The following is a description of a gene set: The chemical reactions and pathways involving a deoxyribonucleotide, a compound consisting of deoxyribonucleoside (a base linked to a deoxyribose sugar) esterified with a phosphate group at either the 3' or 5'-hydroxyl group of the sugar. Mouse Gene Set: GOBP_DEOXYRIBONUCLEOTIDE_METABOLIC_PROCESS species: Mus musculus, and this is the list of marker genes: Tyms, Tbpl1, Nt5c3, Dpyd, Guk1, Dera, Nt5c1a, Cmpk2, Dguok, Dnph1, Nudt16, Ak2, Ak3, Nudt15, Urad, Dck, Rrm2b, Samhd1, Urah, Nt5c, Adk, Dut, Rrm2, Rrm1, Nudt18, Nme2, Dctpp1, Pnp, Uox, Upp1, Upb1, Nme1, Nt5c2 (5'-nucleotidase, cytosolic II), Dtymk, Dctd, Gda, Cda, Nt5m, Oga, Tymp, Cmpk1, Ada, Nme3, Upp2, Tk2, Shmt1 (serine hydroxymethyltransferase 1 (soluble)), Dhfr, Shmt2, Xdh, Dpys